Given this list of marker genes MYF5, MYMX (NCBI Gene Id 101929726), NPHS1, ADGRB1, ACTA1, SHH, LARGE1, BHLHE41, KCNH1, SIX1, SMYD3, SMO, STAC3, RIPOR2, PPP3CB, BCL2, MAPK14, TNFSF14, PLEKHO1, BARX2, SCGB3A1, PLEC, WNT10B, NEO1, PIEZO1, RBM38, SELENON, DNER, CACNA1S, MIR133A1, MYOCD, CD53, PTGFRN, MYOD1, IGF1, GPX1, ATP11A (NCBI Gene Id 84170), CAV3, CAV2, SIK1, MMP14, NOTCH1, CEACAM5, MYH9, MYEF2, BHLHA15, TRIM72, ADAMTS15, NKX2-5, SHOX2, CCN3, HDAC5, NOS1, CDON, HDAC1 (histone deacetylase 1), COL6A1, MYC, MYF6, ERVW-1, ANHX, P2RX2, DOCK1, NFATC2, FKTN, BCL9, CXCL10, MTOR, EHD2, B4GALNT2, CCL8, ACTN3, TBX1, CAPN2, SORT1, PPP3CA, PPIF, CACNA1H, AVPR1A, GDF15, RPL3L, CXCL9, TMEM182, XK, CD81, MEF2C, MIR1-1, IL4R, KLF5, RBM24, TANC1, XBP1, PLPP7, CNTNAP1, CD9, HDAC4, NACA, WNT1, DOCK2, DCAF8 (DDB1 and CUL4 associated factor 8), BIN3, ADGRB3, ADAMTS5, MAML1, SPG11, EHD1, LMOD3, NLN, MIR206, MIR133B, SMYD1, BDNF, HDAC9, HOMER1, DMPK, RYR1, MIR200B, HDAC3, MYMK, DYRK1B, CFLAR, RCAN1, ITGB1, SKI (SKI proto-oncogene), DOCK5, FKRP, MAMSTR, MYORG, MYOG, FLOT1, TMEM119, KEL, CYP26B1, ADAM12, SIX4, KLHL40, FBXO22, ERVFRD-1, PLD3, here is a description of the gene set: The process in which a relatively unspecialized cell acquires specialized features of a myotube cell. Myotube differentiation starts with myoblast fusion and the appearance of specific cell markers (this is the cell development step). Then individual myotubes can fuse to form bigger myotubes and start to contract. Myotubes are multinucleated cells that are formed when proliferating myoblasts exit the cell cycle, differentiate and fuse. Human Gene Set: GOBP_MYOTUBE_DIFFERENTIATION species: Homo sapiens